Given this list of marker genes Bcl9l, Ppp2r5b, Gnb4, Znrf3, Ppp3cb, Dvl1, Rac2, Ppp2r5a, Gng4, Ruvbl1, Kremen2, Ywhaz, Sox6, Lgr5, Arrb2, Calm2, Bcl9, Ppp2r1a, Gng10 (guanine nucleotide binding protein (G protein), gamma 10), Rspo1 (R-spondin 1), Gngt2, Gngt1, Psmd14, Nfatc1 (NCBI Gene Id 72364), Dvl2, Ap2s1, Ryk (receptor-like tyrosine kinase), Wnt5b, Fzd5 (NCBI Gene Id 98335), Ppp3ca, Igfals, Wnt7a, Fzd2, Wnt5a, Lrp6, Dkk4, Psmd3, Hecw1, Gnb2, Akt2, Adrm1, Rps27a, Wls, Wnt3 (wingless-type MMTV integration site family, member 3), Wnt3a, Kras, Usp8, Rhoa, Psmb2, Rspo2, Pfn1, Csnk1a1, Ep300, Psmd12 (NCBI Gene Id 66997), Usp34, Wnt4, Psmc6, Smurf2, Ap2b1, Psmd1, Tle2, Prkcg, Psmd7, Gnb1, Ppp2r5e, Gnb5, Rnf43, Wnt8a, Psmd6, Ubc, Psma4, Tcf7l1, Ctnnbip1, Dkk2, Plcb3, Pde6g, Csnk2a2, Csnk2a1, Psma3, Pip5k1b, Tmed5, Ppp2cb, Gsk3b, Klhl12, Tle3, Pde6b, Tnks, Psmb4, Dact1, Psma6, Ppp2r5c, Uba52rt, Wnt11, Smarca4, Gng7, Sox3, Pard6a, Ubb, Cdc73, Rspo4, Fzd6, Psmd11, Cul3, Sox4, Xiap, Camk2a, Uba52, Psmc3, Psmd2, Ppp3r1, Gnao1, Wnt10a, Smurf1, Amer1, Rbbp5, Akt1, Tcf7, Gng12, Kmt2d, Gng8 (NCBI Gene Id 14709), Calm3, Ppp2r1b, Psmb7, Hdac1 (histone deacetylase 1), Calm1, Wnt16, Pygo1, Lrp5, Dkk1, Cltc (NCBI Gene Id 97762), Psma5, Psma7, Apc, Psma2, Ctbp1, Sox9, Fzd4, Csnk2b (casein kinase 2, beta polypeptide), Wnt2b, Psmc4, Clta, Gng5, Psmd8, Frat1, Psmc5, Frat2, Vps35, Sox13, Gng13, Nlk, Tert, Fzd3, Daam1, Men1, Ap2a1, Sox17, Snx3, Wnt7b, Tle1, Gng3, Fzd7, Psmb6, Rbx1, Rac3, Cby1, Xpo1, Rnf146, Psmd13, Ppp2ca, Kremen1, Cav1, Ror1, Cltb, Plcb2, Sox7, Gnb3, Skp1, Zranb1, Gng2, Chd8, Pygo2, Leo1, Gnat2, Prickle1, Ash2l, Fzd1, Map3k7, Gng11, Plcb1, Axin2, Trrap, Wnt6, Wnt10b, Psmc2, Rspo3, Psmb1, Prkcb, Tcf7l2, Psmb5, Wnt9b, Fzd8, Tle4, Wnt2 (wingless-type MMTV integration site family, member 2), Ctnnb1, Kat5, Vps26a, Psmb3, Lef1, Axin1, Psmc1, Vps29, Wnt9a, Wnt1, Ctbp2, Cul1, Dvl3, Csnk1e, Psma1, Tnks2, Sost, Ppp2r5d, Wnt8b, Rac1, Ap2a2, Ap2m1, here is a description of the gene set: studied in species Mus musculus Mouse Gene Set: REACTOME_SIGNALING_BY_WNT Signaling by WNT